The following is a description of a gene set: Human Gene Set: GSE5589_IL6_KO_VS_IL10_KO_LPS_AND_IL10_STIM_MACROPHAGE_45MIN_DN from publication El Kasmi KC, Holst J, Coffre M, Mielke L, de Pauw A, Lhocine N, Smith AM, Rutschman R, Kaushal D, Shen Y, Suda T, Donnelly RP, Myers MG Jr, Alexander W, Vignali DA, Watowich SS, Ernst M, Hilton DJ, Murray PJ (PMID 17114459) Genes down-regulated in bone marrow-derived macrophages at 45 min of stimulation by IL10 and LPS: IL6 knockout versus IL10 knockout. studied in species Homo sapiens IL-10 or IL-6 stimulation of control 129xC57BL/6 murine bone marrow derived macrophages in the presence of LPS. We used microarrays to detail the global programme of gene expression changes in response to IL-6 or IL-10 stimulation in the presence of lipopolysaccharide. BMDMs were isolated from control, IL-6-/-, and IL-10-/- mice on a 129XBL/6 mixed background mice and differentiated in the presence of CSF-1 for 6-7 days. Cells were scraped and plated in 6 well plates at 2x10e6/well. Cells were washed with complete DMEM and rested for 1-2 hr before stimulation with combinations of IL-10 (10 ng/ml), IL-6 (2 ng/ml) or LPS (100 ng/ml) for 45 min or 180 mins. Complete biological replicates were performed., and this is the list of marker genes: STIMATE, ASB4, FILIP1L (NCBI Gene Id 11259), MCOLN1 (NCBI Gene Id 57192), SLC25A15, TMEM263, KLF10, HAUS4, BLTP3B, OARD1, GRK2, IL1A, KLHL9, NEDD4L, SMAD6, USP16, OSBPL11, KIF7, PLIN2, ANGPTL3, ENGASE, ABHD3, UBR1, ABCD2, UBE2Q2, IL31RA, ELF1 (NCBI Gene Id 1997), PLEKHB2, MED30, ACAA2, NATD1, IL1RN, THBD, HARS2, SMPDL3A, CHD3, IRF2BP2, HSDL2 (hydroxysteroid dehydrogenase like 2), SCARB2, ATP6V1B2, FABP7, ECH1, ANXA2, FAM53B, HADHB, SLC25A20, CELA1, FGF11, DOCK7 (dedicator of cytokinesis 7), ATP13A3, ARHGEF6, CKAP5, KBTBD2, SCOC, LRRC39, ECI2, HBP1, RIPK1, GET1, PLCXD2, UBQLN2, TEX19, SNX9, ITGAV, IRAK2, CPT1A, TREML4, MYSM1, LDHA, PPIP5K1, MED17, TRIM25, HSPA2, SPTLC2, THUMPD2, KANSL1, PDGFC, C4orf46, GPRASP3, TGFBR3, SH3BGRL2, GALNT15, ACP5, DGKZ, ACP6, PAXBP1, DDB2, KLF11, ERMP1, PRICKLE2, PNPO, PRUNE1, SNX10, SLC5A3, ASPA, CENPU, TMEM65, COX20, MGAT4B, ECHDC1, SIRPB1, ETFB, AKR1B1, P2RY14, GSTT2, SEPHS2, POLG2, VAV3, ENPP1, ATP6V0A1, IST1, LNX2, WDFY2, AVPI1, RNF216, EXT1, TBC1D9, AKR1B15, HNRNPH2, XPR1, SUCLG2, NIPA2, SEPTIN9, ICAM4, COL6A1, PDE3B, BRCA1, SLC37A2 (NCBI Gene Id 219855), PTGR2, ANGPTL4, KCTD5, CDK2, TASL, ATP6V0D2, SPAG5, ABHD12, CORO2B, PEX11A, TUSC1 (NCBI Gene Id 389708), OCRL, TPCN2, SLC27A1, PTBP3, SORT1, FHDC1, CASP8, GSPT1, SLC25A51, SLC27A2, MAN2A1, THOC2, H6PD, LPCAT3, GPCPD1, UTRN, HYCC1, TMEM245, ETFA, ZNF182, GLUL, PICALM, ABCG1, BCAP31, HEY1, NET1 (NCBI Gene Id 10276), PLEKHH2, PECAM1, QRICH1, PLA2G6, NR1D2, IL16, ACCS, AXL, SYNE2, GHR, NR2C1, RPRD1B, DCAF6, LIMS2 (LIM zinc finger domain containing 2), TTC38, ALDH9A1, BRAF, ACSF2, IPO8, ULK3, ACTR5, LY75, FABP4, FLCN, SLC18B1, MRPS6, TLE1, HMOX1, TTC39B, PRG4, PTGER2, FRK, SMARCAD1 (NCBI Gene Id 7303), RALGDS